Given this list of marker genes ELOC, POLR2C (NCBI Gene Id 5432), CCNT1, SSRP1, TCEA1, POLR2F, ELOA2, POLR2I, POLR2D, NELFCD, CDK9, POLR2B, CTDP1, SUPT16H, SUPT4H1, NELFE, GTF2F2, SUPT5H, CCNK, POLR2K, NELFA, POLR2H, POLR2G, POLR2J, POLR2A, ELL, ELOA, NELFB (negative elongation factor complex member B), CCNT2, GTF2F1, ELOB, POLR2L, POLR2E (RNA polymerase II, I and III subunit E), here is a description of the gene set: HIV elongation arrest and recovery Human Gene Set: REACTOME_HIV_ELONGATION_ARREST_AND_RECOVERY studied in species Homo sapiens